Given this list of marker genes ERGIC3, NMBR, SSNA1, NEDD4L, MIS18BP1, RASA3, CASP2, STC2, SLC7A1, TRIO, REV3L, ISLR, RAD50, ECH1, NSMCE1, PGLS, STIL, CPNE3, CMTM7, LTB4R, NCAPH (non-SMC condensin I complex subunit H), CCND3 (cyclin D3), HSD17B10, BIN1, PFN2, SFRP1, CSTPP1, ERGIC1, GPR50 (NCBI Gene Id 9248), MAP3K4, ICAM2, LRRC8C, NUMA1, KIF4A, PNKP, CXCR4, ITGB7, IMPA2, AARS1, SAP30L, PTDSS2, HPCAL1, MYO5B, TMX2, APAF1, RMND1, FAAP20, ZNF746, TMEM43, WBP1L, ENTREP3, IRF4, PSMB8, ADGRG1, DGUOK, SDHA, ACAA1, TMPO (NCBI Gene Id 7112), MEIS1, PDE6D, PARN, HOXD10, ITM2B, ATP5IF1, FIGNL1, DDIT4, NPC1, CRYBG1, MEF2C, SIPA1, NUDT16L1, NHERF1, PCBD2, AOC1 (amine oxidase copper containing 1), ACAA2, ABCC9, SLC48A1 (NCBI Gene Id 55652), CUTA (cutA divalent cation tolerance homolog), LBR, CORO1A, RNF145, ASPM, NAA10, MKNK2, FAM53A, DESI1, VAMP8, TUBG1, DDX6, SAAL1, RSU1, ABL1, RBL1, PSTPIP1, PIMREG, NCOA1, USP5, ITSN1, PTEN, UBLCP1, BIRC2, AHRR, CHMP2A, TCEA1, CRTAP, ECHS1 (enoyl-CoA hydratase, short chain 1, NCBI Gene Id 1892), TNK2, TBC1D1, ACO2 (aconitase 2), SLAIN1, SAA1, PIP4K2A, FLI1, ZFYVE19, SAG, NFATC3 (nuclear factor of activated T cells 3), CELA1, VPS26C, GUCA1A, SLBP, RPRD1B, MAP2K5, FOXRED1, ATP13A2, PIM2, DNAJC9, MAP3K3, RNASET2, CDCA7L, TXNDC16, SLC6A13 (NCBI Gene Id 6540, solute carrier family 6 member 13), LAGE3, C1QC, CNR2, PAG1, IDH3G (isocitrate dehydrogenase (NAD(+)) 3 non-catalytic subunit gamma), ING4, LMAN1, XPC, IGBP1, MAP3K8, NUDT5, MYB, IL16, IL27RA, GRK2, SUGP2, MCRIP1, CDC23, FOXO3, ING1, ACYP1, LDB1, CD47, EPB41, MYO1D, ERCC5, ZMYND8, CDKN2C, CYB5A, VRK3, STK25, RPL22, INTS3, NF2, RNF181, GPX4, UBR7, POLG2, FADD (Fas associated via death domain), ANAPC13, CD37, CCNF, SRPK2, COL18A1, SLC11A2, SYNGR4, ZMYND11, NDUFA9, CDC42SE2, XPO7, DUSP19, ARHGAP45, UPF3B, LTBP3, ELOVL5, MTARC2, NFATC2IP (NCBI Gene Id 84901), FAM107B, TFF1, PCID2, SPICE1, CD48, SLC50A1, SHE, NEDD4, PYGB, GSR, PRKACB, TIMELESS, here is a description of the gene set: Human Gene Set: GSE19923_HEB_KO_VS_HEB_AND_E2A_KO_DP_THYMOCYTE_UP Genes up-regulated in double positive thymocytes: TCF12 knockout versus TCF3 and TCF12 knockout. from publication D'Cruz LM, Knell J, Fujimoto JK, Goldrath AW (PMID 20154672) We wanted to test the role of mammalian E proteins E2A and HEB in the development of T cells. Using a conditional deletion system in which these proteins are deleted at the DP stage of T cell development, we compared DP thymocytes deficient for E2A, HEB or both to wild-type thymocytes species: Homo sapiens